The following is a description of a gene set: studied in species Homo sapiens Human Gene Set: HP_ABNORMAL_LYMPHOCYTE_MORPHOLOGY An abnormality of lymphocytes. Abnormal lymphocyte morphology, and this is the list of marker genes: JAK3, TNFRSF13C, ATM, PSMB4, ICOSLG, TBX2, OTULIN, LCP2, MYD88, KMT2D, CD19, TLR8, WAS, ATP6AP2, POMP, FCHO1, PIK3CG, ELF4, IRAK1, CD3G, DCLRE1C (NCBI Gene Id 64421), GINS1, SLC19A1, IKZF3, RFXANK, LBR, DEF6, CASP8, CLN5, IVNS1ABP, BTNL2, CTNNBL1, ZAP70, CBLB, ATRX, NFKB2, TRNT1, IL7R, TERT, CLN3, ITK, ADA2, SEC61A1, ZBTB24, CTLA4, MGAT2, ATP11A, LIG1 (DNA ligase 1), RAG1, ACP5, TNFRSF13B, AP3B1 (adaptor related protein complex 3 subunit beta 1), SOCS1 (NCBI Gene Id 8651), KDM6A, IL36RN, RAG2, SKIC2, IRF2BP2, SPRED2, AGA, DNMT3B, ARPC1B, NBN, GFI1, EPG5, PNP, GATA2, STN1, NEU1, PTEN, PSMB9, DIAPH1, NLRC4, IL21, BLNK (NCBI Gene Id 29760), FNIP1, CORO1A, BACH2, KRAS, GALE, LIG4, ORAI1, SMARCAL1, MTHFD1, IL17RA, SPI1, LCK, TCIRG1, FOXP3 (NCBI Gene Id 50943), AK2, RFX5, SKIC3 (SKI3 subunit of superkiller complex), RAC2, EXTL3, STIM1 (stromal interaction molecule 1), CR2, MAGT1, CD81, RRAS2, PNPLA2, STAT4, ELANE (elastase, neutrophil expressed), C1GALT1C1, MDM4, IKZF1, USP48, PIK3CD, NFKB1, TOM1, NRAS (NRAS proto-oncogene, GTPase), ALG12, SAT1, NCKAP1L, RASGRP1, KLHDC8B (kelch domain containing 8B), RELB, IL6ST, MYC (MYC proto-oncogene, bHLH transcription factor), CD79A, LYST, SGPL1, GLB1, PIK3R1, PPT1, RFXAP, BLM, TLR7, CHD7, RHOH, G6PC3, RMRP, BTK, MALT1, IL6R, CDCA7, IRF1, CARD11, CYBC1, MCM4, MAP3K14, DOCK2, SLC17A5, BRAF, UHRF1, SP110, GTF2H5, HYOU1, AP1S3, CD3D, SPP1, PSMB10, PGM3, NFKBIA, IL7, PRKDC, ADA, NCAPG2, SH2D1A, BCL10, CCBE1, B2M, CD247, TNFAIP3, TNFRSF1B, IRAK4, HLA-DRB1, UNC119, MAN2B1, SLC39A7, RIPK1, MSN, LEP, FBXL4, NR3C1, WIPF1, FAS, IGLL1, TINF2, STING1, XRCC4, CD70, CARD9, NSMCE3, CXCR4, FOXN1, CDH23, USP8, CD8A, FASLG, TCF3, NHEJ1, MCM10, EIF2AK3, NAF1, ADAMTS3, FUCA1, SAMD9, PRIM1, CD28, PTPRC, PRKCD, RPA1, IKBKG (NCBI Gene Id 8517), BCL11B, CIITA, POLD1, REL, SRP19, IGHM, RNASEH2B, IL2RG, IFIH1, HELLS, TPP2, STK4, IL2RA, TET2, IL2RB (interleukin 2 receptor subunit beta), ICOS, MYSM1, TNFSF12, LYN, FOCAD, TP53, TFR2, PLCG2, SASH3, STAT2, POLD3, IKBKB, MS4A1, DCLRE1B, FCGR3A, SYK, XIAP, NAE1, WDR1, CD79B, RNF31, CTPS1, HLA-DPB1 (NCBI Gene Id 3115), PI4KA (NCBI Gene Id 5297), LAT, STAT1, TERC, CASP10, DOCK8, TCN2, KNSTRN, TNFRSF9, RAP1B, LRBA, CD4, CD3E, CLPB, ARHGEF1, LEPR, TTC7A, TTI2, FAT4, LMNB2